Given this list of marker genes HRAS, ITM2C, SPRY3, HECTD4 (HECT domain E3 ubiquitin protein ligase 4), PPP2R2D, MAP4K4, DHH, PPP3CC, TET3, FGFR3, CEP85L, SYNPO, HPCAL4, SCN4B, LRP2BP, CNOT2, MICAL3, WTAP, STK39, MAPK6, AP3M1, TMEM135, LARP4B, SPTBN2, PHOSPHO1, ENSG00000275993, TKTL2, NASP (nuclear autoantigenic sperm protein), UBFD1, EIPR1, PPRC1, HLCS, IL17RD, ZFAT, BTNL9, SRSF8, VASH1, GABBR2, EVA1A, RNF103, LIMD1, NLRP13, CHD8, RPL28, RELA, RGS8, PDHA1, GOLGA4, GAREM1, PKNOX2, CTF1, here is a description of the gene set: Human Gene Set: MIR1306_5P species: Homo sapiens from publication Chen Y, Wang X (PMID 31504780) Genes predicted to be targets of miRBase v22 microRNA hsa-miR-1306-5p in miRDB v6.0 with MirTarget v4 prediction scores > 80 (high confidence targets).